The following is a description of a gene set: species: Homo sapiens Human Gene Set: GOBP_DIGESTIVE_SYSTEM_PROCESS A physical, chemical, or biochemical process carried out by living organisms to break down ingested nutrients into components that may be easily absorbed and directed into metabolism., and this is the list of marker genes: NR1I2, IREB2, CHRM3, AQP1, PNLIP, APOA4, CLDN15, PLS1, SLC46A1, CYP8B1, FABP2, OPRK1, FGF10, TLR4, NEUROD1, CEL, TYMP, GCNT3, RBP4, TFF3, CHRM5 (NCBI Gene Id 1133), APOA2, ZNF830, APOA1, KCNQ1, SNX10, HEPH, VIL1, MOGAT2, LEP, AQP5, NPC1, MUC4 (mucin 4, cell surface associated), CHRM1, VSIG1, IL10RA, CCKBR, STK39, STRAP, SOX9, GHRL, HIP1R, CLDN2, EZR (NCBI Gene Id 7430), COMT, TFF1, HRH2, KCNN4, NKX2-3, CRACD, SLC22A5, WNK3, NOD2, ABCG8, SGK1, TJP2, MDK, SCT, INAVA, UGCG, LIPA, NR1H3, SLC5A1 (NCBI Gene Id 6523), STATH, PRAP1, CD36, F11R, TFF2, NR1H2, ENPP7, ADRA2A, NEGR1, TLR9, WNK1, OXT, DCANP1, SOAT2, PTGER3, HAMP, ACO1, SLC9A4, GHSR, NPC1L1 (NPC1 like intracellular cholesterol transporter 1), LDLR, SCARB1, SLC4A9, VDR, PPP3CA, SLC26A6, NEUROG1, ABCB1, LIMA1, EPB41, SLC2A5, NPPC, IL17A, MUC13, CRH, NPR2, HTR4, LPCAT3, WNK4, ABCG5 (NCBI Gene Id 64240), PBLD, SERPINA3, NMU, SLC26A7 (solute carrier family 26 member 7), MUC6, AKR1C1, NPSR1, MUC2, COPA, TIFAB